Given this list of marker genes APOL1, PRSS40A, LAMB4, FUT6, AHSP, APOBEC3A, AMY1B, POU5F1B, MUC22, SP140L, ZNF716, ERAP2, LINC01553, CCDC168, SPANXN1, MAP1LC3C (NCBI Gene Id 90303), ACSM2B, ZNF221, KRTAP15-1, ZNF492, POM121L7P, TRIM22, OR10K1, GLYATL1, FAM9C, LINC02860, ERVW-1, NDUFV1-DT, PCDH11Y, TSBP1, PIWIL3, LEUTX, PARP15, MGAT4EP, UGT2B15, GRK7, ZIM3, FAM177B, LINC02108, ENSG00000187951, MRPL42P1, PGA3, LINC02864, LINC01550, FCRL4, ZNF705G, here is a description of the gene set: species: Homo sapiens from publication Florio M, Albert M, Taverna E, Namba T, Brandl H, Lewitus E, Haffner C, Sykes A, Wong FK, Peters J, Guhr E, Klemroth S, Prüfer K, Kelso J, Naumann R, Nüsslein I, Dahl A, Lachmann R, Pääbo S, Huttner WB (PMID 25721503) Evolutionary expansion of the human neocortex reflects increased amplification of basal progenitors in the subventricular zone, producing more neurons during fetal corticogenesis. In this work, we analyze the transcriptomes of distinct progenitor subpopulations isolated by a cell polarity-based approach from developing mouse and human neocortex. We identify genes preferentially expressed in human apical and basal radial glia that lack mouse orthologs. Among these, ARHGAP11B has the highest degree of radial glia-specific expression. ARHGAP11B arose from partial duplication of ARHGAP11A (which encodes a Rho guanosine triphosphatase-activating protein) on the human lineage after separation from the chimpanzee lineage. Expression of ARHGAP11B in embryonic mouse neocortex promotes basal progenitor generation and self-renewal and can increase cortical plate area and induce gyrification. Hence, ARHGAP11B may have contributed to evolutionary expansion of human neocortex. Human Gene Set: FLORIO_HUMAN_NEOCORTEX Human-specific genes up-regulated in basal radial glia (bRG) relative to apical radial glia (aRG), and up-regulated in both aRG and bRG relative to neurons.